The following is a description of a gene set: Any process that stops, prevents, or reduces the frequency, rate or extent of Rac protein signal transduction. Human Gene Set: GOBP_NEGATIVE_REGULATION_OF_RAC_PROTEIN_SIGNAL_TRANSDUCTION studied in species Homo sapiens, and this is the list of marker genes: STMN3, MIR21, ARHGAP44, ARHGAP24, NF1, MIR29B1